The following is a description of a gene set: Human Gene Set: GSE39864_WT_VS_GATA3_KO_TREG_DN The transcription factor Foxp3 is indispensible for the differentiation and function of regulatory T cells (Treg cells). To gain insights into the molecular mechanisms of Foxp3 mediated gene expression we purified Foxp3 complexes and explored their composition. Biochemical and mass-spectrometric analyses revealed that Foxp3 forms multi-protein complexes of 400-800 kDa or larger and identified 361 associated proteins ~30% of which are transcription-related. Foxp3 directly regulates expression of a large proportion of the genes encoding its co-factors. Reciprocally, some transcription factor partners of Foxp3 facilitate its expression. Functional analysis of Foxp3 cooperation with one such partner, Gata3, provided further evidence for a network of transcriptional regulation afforded by Foxp3 and its associates to control distinct aspects of Treg cell biology. Gene expression profile of Treg specific knock-out of Gata3 vs. their littermate controls were analyzed to gain insight into Gata3 dependendent genes in Treg cells. Genes down-regulated in T reg cells: wildtype versus GATA3 knockout. from publication Rudra D, deRoos P, Chaudhry A, Niec RE, Arvey A, Samstein RM, Leslie C, Shaffer SA, Goodlett DR, Rudensky AY (PMID 22922362) studied in species Homo sapiens, and this is the list of marker genes: DDB1, NME3, CEBPZOS, AHCYL1, SPTAN1, DPM3, RSU1, BRD4, PLXNB2, ADGRE1, OTULINL, ARHGAP39, MRPS21, ATP1B3, GPSM3, ANAPC5, STMP1, SLC25A4, SQSTM1, ACOT13, CDK9, ATP5F1E, NDUFB5, ALDH2, PCYT1A, HPGD, ARHGAP45, CLCN4, GTF2I, ZNF740, DENND5A, SRP9, PHTF1, UBE2I, ORMDL3, PCK2, ST8SIA4, SLC1A1, RAD50, TRIM47, WDR48, BNIP3L, LRWD1, CCR2, EEF2, HAUS3, LAMTOR4, CREG1, RERE, RPL7A, NAA38, SPART, NDUFB11, PKIG, KIF23, PMM1, SFR1, CDK2AP2, BPHL, CST3, GLO1, ALDH9A1, TMEM141, FAU, AMPD3, TSC22D1, MLST8, NDUFA8, RCC2 (NCBI Gene Id 55920), TOR1B, PRKAG1, PON2, IGF1, C12orf57, DRG1, APOE, RPS18, ANG, HDAC5, SLC38A2, KPNB1, SPTSSA, PRDX4, FADS1, CNOT1, RNASET2, UQCRQ, PPIB, CASP9, INTS3, COPRS, BCKDK, CARD19, MAN2B1, DHRS3 (NCBI Gene Id 9249), IGBP1, RNASEH2C (ribonuclease H2 subunit C), BTG2, CACUL1 (CDK2 associated cullin domain 1), SNRNP25, SLU7, ACLY, USE1, CYB5R4, ARL4C, NCOR2, CYB5A, MRPL42, LSM4, APOC2, BCKDHB, PHPT1, HMGA1, MIF4GD, ACADM, ABCB8 (NCBI Gene Id 11194), KGD4, TYROBP, KANSL2, PHKG2, FES, ADD1, ERMP1, DCTN3, TMEM160, FBXO45, RUFY1, CRIP1, ATP5PF, RASA3, DHX9, NAXE, IDH3G, SMAGP, PLIN2, SYNGR1, FAM13B, APLP2, ROMO1, HAGH, RMND5A, MRPL24 (NCBI Gene Id 79590), ASAH1, ARL14EP, SELENOK, GRSF1, MKI67, ADCY9, XPOT, HIGD2A, ST3GAL5, ANAPC16, TMEM223, PTP4A2, SBNO1, BMP8B, UROD, PPP1R21, CUEDC1, ARRB1, BCKDHA, MRPS24, IPO11, MEPCE (NCBI Gene Id 56257), NDUFA13, C6orf62, ARL1, MLEC, PKD2, UQCR11, SLC27A1, NPM1, GNA12, CORO1A, GALK2, RELL1, RGL2, MCM5, AMMECR1L, RPF2, SKIC2, FUT8, SYNCRIP, ANAPC13, UBL3, TGIF1, HNRNPH1, FAM89B, UQCRHL, C4B, LIMA1, RNF166, SIGMAR1, VAMP8, SLMAP, RAB3D, CSF1R, SH3BP5, PTDSS1, ALG5